The following is a description of a gene set: A protein ligase complex that enables protein sumoylation. Consists of a SUMO-protein transferase and other proteins that may confer substrate specificity of the complex. Human Gene Set: GOCC_SUMO_LIGASE_COMPLEX species: Homo sapiens, and this is the list of marker genes: RANGAP1, SMC6 (NCBI Gene Id 79677), RANBP2, NSMCE4A, SUMO4, SLF2, SLF1, NSMCE1, UBE2I, NSMCE3, NSMCE2, SMC5, EID3